Given this list of marker genes IL17RA, TIRAP, IL17F, IL17A (NCBI Gene Id 94918), TRPV4, here is a description of the gene set: studied in species Homo sapiens Human Gene Set: GOBP_POSITIVE_REGULATION_OF_CHEMOKINE_C_X_C_MOTIF_LIGAND_1_PRODUCTION Any process that activates or increases the frequency, rate or extent of chemokine (C-X-C motif) ligand 1 production.